The following is a description of a gene set: Mouse Gene Set: GOBP_REGULATION_OF_POSTSYNAPSE_ORGANIZATION species: Mus musculus Any process that modulates the physical form of a postsynapse., and this is the list of marker genes: Lrfn4, Cux2, Nrxn2, Lrp4, Arhgap44, Asic1, Sema3f, Abi3, Cdk5r1, Prnp, Dbn1, Mfn1, Lrrc4b, Dbnl, Srcin1, Lzts3, Arhgap22, Vps35, Carmil3, Nedd8, Lzts1, Cdc42 (NCBI Gene Id 12540), Kalrn, Shank3, Pum2, Stau2, Prickle1, Nf1, Nckipsd, Slc30a1, Cask, Lrfn2, Arc, Plppr4, Dclk1, Eef2k (NCBI Gene Id 97404), Rapgef4, Pten, Psd, Asic2, Zdhhc8, Bhlhb9, Ghsr, Trim47, Abi3bp, Abhd17a, Vhl, Cript, Numbl, Caprin2, Cyfip2, Dock1, Slc12a5, Cbln1, Tanc1, Rheb, Nedd9, Tanc2, Mark1, Marcks, Dhx36, Shank2, Abhd17b, Efna1, Map1b, Fgfr1, Nrp2, Il1rap, Ube2m, Cfl1, Ptk2b, Ppfia2, Wnt5a, Tsc2, Flrt2, Actr2 (NCBI Gene Id 66713), Syndig1 (NCBI Gene Id 99331), Homer1, Elmo1, Itsn1, Adam10, Apoe, Epha7, Usp9x, Psen1, Grin1, Dtnbp1, Rbmx, Arhgap33, Ncan, Caskin1 (CASK interacting protein 1), S1pr2, Iqgap1 (IQ motif containing GTPase activating protein 1), Psen2, Disc1, Ptprf, Rtn4, Ghrl, Nae1, Htr4, Ptprs, Nlgn1, Grid1, Prickle2, Afdn, Fam107a, Mark2, Lrrtm1, Hnrnpk, Numb, Pafah1b1, Dnm1l, Dock4, Wasl, Tiam1, Ptpn1, Opa1, Baiap2, Itpka, Asap1, Kif1a, Abhd17c, Rac3, Cpeb3, Ins2, Arhgef15, Lats1, Srgap3, Pdlim5, Zdhhc15, Ube3a, Ptprd, Rhog, Crmp1, Zmynd8, Dvl1, Il1rapl1, Dcx, Ube3b, Sema4c, Nectin3, Ins1, Sipa1l1, Cc2d1a, Gna13, Ror2, Dnm3, Dact1, Lrrk2, Camk2b, Cdkl5, Lrp8, Nrxn1, Lrfn1, Actr3, Hspa8, Arf4, Wnt7a, Ephb2, Hnrnpm, Rps6ka5, Chmp2b, Rac1, Zfp804a, Nrcam (neuronal cell adhesion molecule), Grid2 (NCBI Gene Id 94324), Fcgr2b, Rtn4r, Dgkb, Akt1 (NCBI Gene Id 268604), Neurl1a, Cdh2, Lrrtm2, Ppp1r9a, Caprin1, Reln, Abi2, Fyn, Pak3, App, Cdk5, Grin2b, Dock10, Nlgn3, Epha4, Sigmar1, Ppp1r9b, Mfn2, Taok2, Xlr3b, Ngef